The following is a description of a gene set: Binding to a BH3 protein domain, present in Bcl-2 family members. The BH3 domain is a potent death domain and has an important role in protein-protein interactions and in cell death. Mouse Gene Set: GOMF_BH3_DOMAIN_BINDING studied in species Mus musculus, and this is the list of marker genes: Irgm2, Mcl1, Bcl2l1, Igtp, Irgm1, Rack1, Bax, Bcl2